Given this list of marker genes SLC25A25, SESN3, FOXN3, ABCE1, C2orf15 (chromosome 2 open reading frame 15), CIC, SEMA4F, SLITRK4, LACTB, SLC16A7, NDUFA12, PHLDA1, SMAD7, RAB33B, CAPZB, PCDHGB7, PTPN14, RB1CC1, IRAK4, NUP43, PCDHAC2, CNTN5, AIDA, VEZF1, PHKB, GSPT1, HECTD2, IL23R, SEMA6A, DSTN, ZNF74, TENT5C, C17orf75, CPEB2 (NCBI Gene Id 285549), PCDHAC1, EPB41L1, LYRM7, LYSMD3, THUMPD1, ODAPH, NPAT, TMEM267, PAX2, DUSP13B, THADA, SOX6, RBMS1, ITPRIPL2, PCDH19, LATS1, PDE7A, AMER2, SERTAD2, XPO1, PTPRM, SLC2A3, SP8, IRX5, GNAQ, CTC1, ACTMAP, FPGT-TNNI3K, TYW1, CDYL, TET1, ANKRD12, ZNF354C, RALA (NCBI Gene Id 5898), APCDD1, ATP11C, KCTD1, COLCA1, ATXN7, NBEA, IL12B, PSD3, MZT1, TXNDC11, SKI, ZNF546, BCL2, ATP6V0E1, SHC1, MAP3K8, CDC14B, SIX3, WWP1, ANGPT1, PTPN2, DENND1B, STEAP2, VCPIP1, PGRMC1, CCDC9B, TMEM43, NRXN1, RAB30, CRTC1, ANK3, PHF13, NR2C2 (nuclear receptor subfamily 2 group C member 2), SKIC3, C1QTNF9, DUSP13A, MFHAS1, DOC2A, PGR, SLC5A12, ZNF148, KCNMA1 (NCBI Gene Id 3778), PDS5A, GABRB2, GATM, HIPK1, SETD9, CTH, CCDC88A (NCBI Gene Id 731560), ATP2A2, LIN7C, ZFP36L1, FAXC, AMPH, ANKS1B, BCL7A, SALL4, C16orf87, MEF2C, RUNX2, SDAD1, PCDHA8, DCUN1D1, MAP6D1, CTNNA1, PLEKHA3, NR3C2, CDK19, IFT80, NWD1, TAGLN3, DCAF5, ANKRD52, HOXC13, VASH2, FRS2, FLRT3, NUTF2 (nuclear transport factor 2), TLCD4, CDC42EP3, TNNI3K (TNNI3 interacting kinase), NWD2, PCDHA9, SLC26A7, PCDHGA5, BAHCC1, TTN, JAKMIP3, RAB3C, IGFBP1, GLCCI1, FGFR3, PCDHGA8, USP49, ZDHHC2, PIK3R1 (phosphoinositide-3-kinase regulatory subunit 1), FHIP1A, SLC4A7, FAT3, GALNT3, VPS26A, HNRNPK, BCL11B, BEST3, ARFGEF3, PCDHGA9, CACNA1C, SP3, ARL17A, BRWD3, PCDHGB2, PCDHA12, PI15, BPTF, NKAIN3, ELOVL6, PATZ1, HBS1L, UNK, ONECUT2, TET2, PURA, WDFY3, IKZF5, CNTN4, SEL1L, ADRA1A, ITGBL1, RAB8B, VEPH1, GTF3C3, CNN3, CCR6, CACNA2D1, PCDHA6, ZEB2, TRPS1, ZNF275, CEP170, RBM41, TAOK1, DCK, PDCD5, QKI, PKD2, S1PR3, PCDHGB5, PCDHA1, CELF1, CGGBP1, MAOA, WAC, SPTBN4, NDUFA10, SGCD, PCDHA5, XIAP, EPHA8, CNMD, CHML, VIPAS39, FAM124A, OPRM1, H3-5, KCNB1, FAM13B, SLC5A5, LRRN1, FOXR2, ZNF619, CHMP2B, AGFG1, PCDH7, FGF14, USP28, KAT2B, MACROD2, SPOPL, CAMK2A, UBE2K, CLRN1, DAB2IP, CTTNBP2NL, DNAJB5, PCDHA13, MSRB3, IGF1, TFRC, TTF1, KDSR, DCLK1, EDN3, PCDHA10, ELK3, PPM1K, SLC7A6, TAF8, GEM (GTP binding protein overexpressed in skeletal muscle), KLF13, ST6GALNAC5 (NCBI Gene Id 81849), USP6NL, FAM168B, DKK2, LRIG3, PDS5B, SGMS1, MSI2, PRKCB, TIGIT, CCBE1, WAPL, UTRN, EDN1, FBXO8, VSTM2A, PCDHGA3, UBN2, MOV10, ANKRD36B, PRTFDC1, SIM2, ZSWIM6, PTCH1, CAPZA2, KCNQ4, REEP1, SATB1, SAR1B, C12orf50, ITFG1, ADAM23, SORBS2, ZMAT2, PABPC5, PCDHA3, PCDHA2, UBE2W, ARID1A, LIN28B, DEGS1, FSD2, IRF2, C2orf69, RPF1, TMEM59, UBE2V2, TFPI2, NMT2, UBR7 (ubiquitin protein ligase E3 component n-recognin 7), PCDHGA6, PCDHGA10, SLC2A12, AUTS2, HACD1, INTS13, HEY2, ZFP1, RBPMS2, KCNH7, RICTOR, PCDHGA1, PIP4P2, ANKRD46, SLC39A8, MICAL3, ARK2C, ME1, RPS6KB1, ATF2, ZDHHC17, MGLL, KCNIP4, EXOC1, NFIB, PALLD, TMSB4X, SOWAHC, TAB3, CCDC50, GGNBP2, JADE1, LRP6, PAG1, TMEM260, TENT4B, SLC9A9, RCAN2 (NCBI Gene Id 221402), TXNDC15 (NCBI Gene Id 79770), EPHB1, F2R, CLNK, SYN1, FOXO3, PCDHA7, PCSK5, NOVA1 (NOVA alternative splicing regulator 1), GMFB, UNC13A, PPHLN1, PCDHGB4, MAP3K1, C18orf63, NRBF2, RALGPS2, FUT9, ENC1, CADM2, SPIN4, KCNJ16, FLT1, SPIRE1, NMD3, CACNA1E, NYAP2, PDE10A, CAMTA1, PMP2, PTPRE, INO80D, CCNYL1, IL17RB, KLF7, VEGFC, LHFPL1, GABRA4, ZBTB2, BMAL1, CHST5, ERI1, AFF2, FBXL4, LIN54, GPR37, PPP4R2, PCDHGA11, DSE, PKHD1, CAMK4, PCDHGB3, KCNN3, SPARCL1, AURKA (NCBI Gene Id 8465), OGG1, FHL5, SEC14L1, PITPNB, PCDHA11, PCDHGA2, TBC1D19, OTUD1, MRAP, SNTB2, CCNF (NCBI Gene Id 899), RASGRF2, PCDHGC4, ANGPTL3, PPP1R1C, PSMA8, AADAT, ACSL4, CBLIF, ADAM19, PCDHA4, CCDC91, BACH2, AGO3, PCDHGC3, ENDOD1, ABHD3, THAP6, UBFD1, DCUN1D5, PCDHGC5, TAGAP, CRTAM, PDE12, ZNF703, DLG2, SUN2, ANO8, OXR1, SLC17A6, ELK4, PABPC1, FNDC3B (NCBI Gene Id 64778), GRIK2, EPHA3, PATE4, NUDT5, SLIT2, TCERG1L (transcription elongation regulator 1 like), CBLB, CS (NCBI Gene Id 94822), IRF2BPL, ELOC, NAA15, PCDHGB6, ANO5, USP9X, TMEM64, CNOT7, TNPO1, PCDHGB1, PLCB4, HCN1, SOAT1 (sterol O-acyltransferase 1), CNIH1 (NCBI Gene Id 10175), ABCB5 (ATP binding cassette subfamily B member 5), OSBPL3, PCDHGA4, ETS1, NFYB, GRB2, PTBP1, SRI, JAG1, RPL22, CHIC1 (NCBI Gene Id 53344), NFIC, UBAC2, CSNK1G3, SPTSSB, AGPAT5, P2RY1, OSBPL6, IFFO2, KSR1, TMEM200A, C21orf91, PPP4R4, KCNMB2, KCND2, KCNQ3, WWC2, SEPTIN8, TMTC4, MAST4, NFE2L2, CASP6, PCDHGA12, CNTNAP3B, NEDD1, TYW1B, AK5, C9orf40, ZNF570, CHL1, PABPC3, TNRC6B, RARG, HSP90AB1, KCNV1, RAI14, APC, PCDHGA7, APPL1, NFE2L3, EPC2, CDC73, ARID4A, RBMS3, CAPRIN1 (NCBI Gene Id 4076), PLXNA4, METTL9, KLHL5, LRRC2, DAB2, GMFG (glia maturation factor gamma), PTER, here is a description of the gene set: from publication Chen Y, Wang X (PMID 31504780) studied in species Homo sapiens Genes predicted to be targets of miRBase v22 microRNA hsa-miR-3680-3p in miRDB v6.0 with MirTarget v4 prediction scores > 80 (high confidence targets). Human Gene Set: MIR3680_3P